The following is a description of a gene set: studied in species Mus musculus A triglyceride-rich lipoprotein particle that typically contains APOB100, APOE and APOCs and has a density of 1.006-1.019 g/ml and a diameter of between 25-30 nm. IDL particles are found in blood and are formed by the delipidation of very-low-density lipoprotein particles (VLDL). IDL particles are removed from blood by the liver, following binding to the APOE receptor, or are converted to low-density lipoprotein (LDL). Mouse Gene Set: GOCC_INTERMEDIATE_DENSITY_LIPOPROTEIN_PARTICLE, and this is the list of marker genes: Apoc3, App, Apoe, Apoc2 (NCBI Gene Id 11813), Apob (apolipoprotein B), Apoc2l, Apoa1